Given this list of marker genes MRGPRF, PRRX1, LINC00968, DEPDC7, IL1R1, RAB27B, PRG4, ETV1, TOP2A, NUSAP1, MAB21L2, CXCL12, CHI3L2, STC2, PTGS1, PDK1, LPXN, SOBP, MAP3K4-AS1, SRPX, RRM2, CDCP1, NAP1L1, STEAP1B, BEND6 (NCBI Gene Id 221336), DEPDC1, SVEP1, CXCL6, EBF1, IGFBP6, TANC2, KITLG, PDE1A, SFR1, DPYD, AVPI1, COL14A1, APCDD1L, SERPING1, LINC00840, ZDHHC2, PDE4B, GSAP, CDCA3, DNM3OS, GNG2, RNF24, CUL4B, IL13RA2, CCBE1, HAS3, BICC1, CD44, OSR1, GXYLT2, DHRS3, CHI3L1, SLC2A12, PLCB1, F2RL1, PDK4, LAMA4, GATA6, CLU, FAM83D, PDZRN3, PTN, FAM111A-DT, MIR31HG, DPYSL3, TNFRSF19, HEG1, CEP55, NRP1, PPP1R3C, PSD3, HAS2, PDE7B, COL10A1, CLDN11, KCNJ15, ADAM12, PBK, MOXD1, HGF (NCBI Gene Id 317720), GALNT15, FGF7, SMKR1 (NCBI Gene Id 100291710), SCRG1, CSGALNACT1, RARRES1, STC1 (NCBI Gene Id 82914), TSHZ1, ANLN, SLC2A5, TGFBR3, ITPR3, PDGFRA, TMEM158, GULP1, ECM1, MIR210, GPC6, PPL, VCAN, RPS6KA2, BMP4, LURAP1L, BDKRB1 (bradykinin receptor B1), BMAL2, CCN4, KCTD4, NEDD4L, LXN, BNC2, SLIT3, SFRP4, NREP, PLPP3, GFPT2, CCN5, TMEM171, PTGFR, FBLN1, ASPM, BIRC5, LUM, ECM2, NR1D2, RUNX2, SPON1, GALNT12, GPER1, FAR2, COL6A2, PTGER2, MME, HNMT, GPSM2, SNX9, PIEZO2, FST, MIR100HG, DCN, DLGAP5, FIBIN, PRC1, ANXA10, CLGN, ALDH1A3, SHCBP1, IFT80, CA12, PCLAF, SRGAP1, BUB1B, CRYBG1, C1R, IGF2, CARD10, SCARA3, EGFR, ZNF503, ZNF521, VEPH1, LRRFIP1, PAMR1, MELTF, PCOLCE2, GLCCI1, KRTAP1-5, CEP126, PTGIS, NAMPT, HLA-DPA1, LACC1, MIR214, ADORA2B, LINC00511, MMP16, ABHD2, GDF5, ZNF395, TRIOBP, KCNK2, BACE1, C1S, FHOD3, ASPHD2, WLS, GLT8D2, SLC12A8, NRP2, HEPH, DUSP4, here is a description of the gene set: Genes down-regulated in mesenchymal stem cells (MSC) engineered to express EWS-FLI1 fusion protein. Human Gene Set: RIGGI_EWING_SARCOMA_PROGENITOR_DN Ewing's sarcoma family tumors (ESFT) express the EWS-FLI-1 fusion gene generated by the chromosomal translocation t(11;22)(q24;q12). Expression of the EWS-FLI-1 fusion protein in a permissive cellular environment is believed to play a key role in ESFT pathogenesis. However, EWS-FLI-1 induces growth arrest or apoptosis in differentiated primary cells, and the identity of permissive primary human cells that can support its expression and function has until now remained elusive. Here we show that expression of EWS-FLI-1 in human mesenchymal stem cells (hMSC) is not only stably maintained without inhibiting proliferation but also induces a gene expression profile bearing striking similarity to that of ESFT, including genes that are among the highest ESFT discriminators. Expression of EWS-FLI-1 in hMSCs may recapitulate the initial steps of Ewing's sarcoma development, allowing identification of genes that play an important role early in its pathogenesis. Among relevant candidate transcripts induced by EWS-FLI-1 in hMSCs, we found the polycomb group gene EZH2, which we show to play a critical role in Ewing's sarcoma growth. These observations are consistent with our recent findings using mouse mesenchymal progenitor cells and provide compelling evidence that hMSCs are candidate cells of origin of ESFT. species: Homo sapiens from publication Riggi N, Suvà ML, Suvà D, Cironi L, Provero P, Tercier S, Joseph JM, Stehle JC, Baumer K, Kindler V, Stamenkovic I (PMID 18381423)